Given this list of marker genes TCHH, TGM3, TP63, SKIC2, HRURF, PADI3, SKIC3, here is a description of the gene set: species: Homo sapiens Human Gene Set: HP_UNCOMBABLE_HAIR Uncombable hair Hair that is disorderly, stands out from the scalp, and cannot be combed flat.